Given this list of marker genes RAD51C, SWI5, XRCC2, XRCC3, RAD51B, RAD51D, SFR1, here is a description of the gene set: A protein complex containing accessory proteins which bind a recombinase (e.g. Rad51) and bind single-stranded DNA (ssDNA), and promote nucleation of the recombinase onto ssDNA through facilitating recombinase-RPA exchange. Human Gene Set: GOCC_DNA_RECOMBINASE_MEDIATOR_COMPLEX studied in species Homo sapiens